The following is a description of a gene set: part of: Cell junction organization studied in species Homo sapiens Reactome Pathway: Type I hemidesmosome assembly Hemidesmosomes (HDs) are specialized multiprotein junctional complexes that connect the keratin cytoskeleton of epithelial cells to the extracellular matrix and play a critical role in the maintenance of tissue structure and integrity. HDs mediate adhesion of epithelial cells to the underlying basement membrane in stratified squamous, transitional and pseudostratified epithelia. Classical Type I HDs are found in stratified and pseudo-stratified epithelia, such as the skin, and contain a6b4, plectin, tetraspanin CD151 and the bullous pemphigoid (BP) antigens BP180 and BP230. While HDs function in promoting stable adhesion, they are highly dynamic structures that are able to disassemble quickly, for example, during cell division, differentiation, or migration (see Margadant et al, 2008)., and this is the list of marker genes: ITGA6, ITGB4, LAMA3, COL17A1, KRT5, KRT14, DST, CD151, LAMC2, PLEC, LAMB3